The following is a description of a gene set: After positive selection in the thymus, the newly generated single positive (SP) thymocytes are phenotypically and functionally immature and undergo apoptosis upon antigen stimulation. In the thymic medullary microenvironment, SP cells progressively acquire immunocompetence. Negative selection to remove autoreactive T cells also occur at this stage. We have defined four subsets of CD4 SP, namely, SP1, SP2, SP3, and SP4 that follow a functional maturation program and a sequential emergence during mouse ontogeny.We used microarray to detail the global programm of gene expression during the maturation of murine CD4 single positive thymocytes species: Homo sapiens from publication Teng F, Zhou Y, Jin R, Chen Y, Pei X, Liu Y, Dong J, Wang W, Pang X, Qian X, Chen WF, Zhang Y, Ge Q (PMID 22022412) Human Gene Set: GSE30083_SP1_VS_SP2_THYMOCYTE_UP Genes up-regulated in comparison of SP1 thymocytes versus SP2 thymocytes., and this is the list of marker genes: MTF2, IL1R2, B3GNT5, ATP6V1G2, HFE, BPGM, PRXL2B, SHMT2, RNF216, C1R, SMIM3, FAM43A, HDC, RALB, PODXL2, CYTH2, EMID1, EGLN3, C9orf43, ARMCX6, SLC3A2, TCF4, CBR3, ALDH7A1, RTKN, CXCL10, MYOCD, ARHGAP26, FOXJ1, SUPV3L1, TNFAIP2, HACD1, ALDH2, PGAP3, REN, RBM22, GSC, DPM1, ICAM1 (intercellular adhesion molecule 1), LAMC1, IFT57, BMAL1, PAFAH1B3, GRK3, TRIB1, LRRC42, HES1, FGF7, LRRK1, ANGPTL2, NXN, GAA, NUCB1, PDZD11, EEFSEC, ADA, RASD1, TRAT1, PPT1, FAM171A1, PRKAR2B, PPP1R15A, FOXB1, PDGFRB, PLA2G12A, SPX, RNF130, FOS, AGPAT4, HEY1, GRIA4, P3H4, PLK3, IGSF6, MRPS30, LHFPL3, RBM19, NUFIP1, BYSL, ELP6, BCL7B, TVP23A, RRS1, RWDD3, CALML4, KCNK1, SLCO4A1, TBC1D13, C8G, CDK20, USP11, SMARCE1, CACNA2D1, C9orf40, CWC27, ANXA10, ENO2, KAT5, SLC31A1, STRA8, DMWD, POLR3H, ZFTA, PAPLN, SEPTIN4 (septin 4), TDRKH, SEMA7A, GLB1, SPTY2D1, VMA21, TCF7L2, ZDHHC22, JPH1, RAPSN, CORO2A, SGK1, CNPY3, SH3BP4, SPRYD4, ELOA, LMCD1, PKNOX2, SNRNP35, GGT7, DYNLT5, CLHC1, TMEM163 (NCBI Gene Id 81615), LAPTM4B, MYO1C, UBD, MEDAG (NCBI Gene Id 84935), BAIAP3, MARCKS, COPS8, TIMD4, SAXO1, C8orf82, FLOT1, PRRT1, NR1H4, GOLM2, PLEKHO1, NECAP1, GALE, NACC1, FBXO8, PTPRK, OPN1SW, APEX1, ACY3, AIF1, ALDH3B1, PTPN14, CEP250, VPS18, MAPK6, CCDC86, GNA15, ZNF711, CKMT2, REEP2, KRT76, STOM, PLXDC2, GSS, AP3S1, TMEM222, CITED4 (NCBI Gene Id 163732), SCN4B, CD79B, GLIPR1L2, FBLN2, SOWAHC, MRM3, ABCC5, RNPEP, LSS, TMEM120B, HK2, TASP1, PPP1R2P1, SERTAD4, RAB5A, BLMH, GJB6, NOP2, TSPAN6, CATSPERZ, SLC2A4, AS3MT, CCR1, AICDA, CHRNA9, HCN3, FABP2, PTOV1, DIPK1B, PPAN, PKIB, PIGR